Given this list of marker genes NADK2, DTX4, ZBTB20, CREB1, RIPOR2, CACNA1C, EDEM3, DNAJB11, BIRC6, MFSD14B, TMEM169, HTR6, BDNF, SIDT1, TFB1M, U2SURP, PEX19, PRR3, TET1, ARMC8, PIGA, HNF4G, SACS, PRRC2C, CPEB3 (NCBI Gene Id 22849), MANEAL, RNF152, SAP30L, KDM2A, NKX6-3, HIC2, SPATS2L, ADAMTS2, CRX, DENND6A, AGAP1, ARHGDIA, ELOVL5, GID8, IHO1 (interactor of HORMAD1 1), COL11A1, PROM1, COL7A1, NFE4, FAM131B, FBXL20, NFIA, ING2, CARD19, FOS, PACS2, SCN3B, TBC1D24, SLC1A3, JARID2, EHMT1, SH3RF3, LARP1, ANKRD49, ZHX1, TUBA1A (NCBI Gene Id 95407), SRSF2, ATP5MC1, MEST, TEAD1, CPD, SLC30A3, DBT, AP4E1, CPS1, ZNF704, ACTMAP, NASP, CSPG4, LASP1, NSD2, RIMS3, SERPINH1, MED12L, ASXL3, KLHDC10, FAM168A, NFAT5, BIVM, CAMK2G, DCLRE1A, NFATC3, SUB1 (SUB1 regulator of transcription), PPM1D, PRR14L, ESRRG, ZBTB34, NANOS1, CD2AP, PLPPR4, AGFG1, SIX5, UBAC2, PDHX (pyruvate dehydrogenase complex component X), FGFR2, ISL1, FKBP1A, CDC7, ZHX3, ADAMTS17, WDFY1, ARFGAP1, HMBOX1, RBAK (RB associated KRAB zinc finger), SNX33, ING4, DOK4, PI15, DIO2, MSL2, ZNF592, TSC22D3, ZNF783, ETNK2, CTTNBP2NL, ANGPTL4, PPP1R3D, TBC1D4, ARRDC3, KDM5A, ZNF813, ZNF827, CTNS, MXD1, PSAT1, GULP1, GPR156 (G protein-coupled receptor 156), STX1A, ZNF468, SUN1, BCL7A (NCBI Gene Id 605), TRIM16, SLC7A5, BLMH, CCDC62, GALNT1, GP1BB, OSBP, CDK5R2, HMGCS1, TRAM2, COL5A3, CHMP6 (charged multivesicular body protein 6), TRIM16L, AKT2, TBCEL (tubulin folding cofactor E like), SLC39A10, NAA40, DOT1L, ASCC1, ARHGEF19, FREM1, CCND2 (NCBI Gene Id 894), NUCKS1, PCYT1B, CPE, PEX5, MGA, PPARD, KLHL8, FAM135A, HAPLN1, TNRC18, PITPNM3 (PITPNM family member 3), ADGRA2, CAVIN1, YIF1B, PHF21A (NCBI Gene Id 51317), SS18L1, ZNF131 (zinc finger protein 131), NAV1, TET2, RNF150, PANK1, CDCA4, DIXDC1, C1orf131, GARRE1, RBFOX2, SENP1, SPTY2D1, MIER3, SOCS7, LDLRAP1, UBTD2, ZBTB5, XXYLT1, ZNF761, LOX, ERI2, MLLT11, WDR26, AGPAT4, PPP2R2D, MTPN, TET3, GPHN, COL19A1, ENPP2, TPX2, C5orf24, UBE2V1, HERC4, TBX21, COL1A2, SNX4, TRIB2, CAMK1D, MYL6, NAV3, PRDM13, SMPD3, HBEGF, MAPKBP1, C11orf87, VHL, EXTL2, PABIR3, TCL1B, PPP4R3B, ADAMTS15, TLX2 (T cell leukemia homeobox 2), ZNF765, DKK1, HEPACAM, ECHDC2, TMEM135, CRMP1, SESN1, DERL2, XKR6, FRAS1, MAML3, DDHD1, HMGCR, PRRT4, NDUFS6, PTEN, ROCK1, PSME4, MYADM, GM2A, AK2, FBXO45, MAP2K4, ATP6V1A, here is a description of the gene set: Genes predicted to be targets of miRBase v22 microRNA hsa-miR-3065-3p in miRDB v6.0 with MirTarget v4 prediction scores > 80 (high confidence targets). Human Gene Set: MIR3065_3P from publication Chen Y, Wang X (PMID 31504780) species: Homo sapiens